The following is a description of a gene set: Human Gene Set: HP_NEOPLASM_OF_THE_INNER_EAR Neoplasm of the inner ear A tumor (abnormal growth of tissue) of the inner ear. studied in species Homo sapiens, and this is the list of marker genes: HRAS, KARS1, KRIT1, NF2, COQ6, CCND1, CCM2, VHL, SPRED1, PIK3CA, LZTR1, PDCD10, SMARCB1